Given this list of marker genes OSTC, TMEM258, ST6GALNAC2, PRKCSH, OST4, MGAT4C, MAGT1, EDEM2, MGAT4A, ST6GAL1, CANX, ST6GALNAC4, RPN2, MAN2A1, DAD1, MGAT1, ZDHHC3, ZDHHC8, MAN1B1, STT3A, MGAT4B, GOLGA7, MOGS, RPN1, FUT8, DDOST, GANAB, MGAT2, ZDHHC9, STT3B, MGAT5, TUSC3, ST3GAL3, ZDHHC5, ST3GAL1, ST3GAL4, ZDHHC2, ST6GALNAC3, ST3GAL2, ZDHHC11, ZDHHC20, here is a description of the gene set: species: Homo sapiens Maturation of spike protein Human Gene Set: REACTOME_MATURATION_OF_SARS_COV_2_SPIKE_PROTEIN